The following is a description of a gene set: Global Genome Nucleotide Excision Repair (GG-NER) Mouse Gene Set: REACTOME_GLOBAL_GENOME_NUCLEOTIDE_EXCISION_REPAIR_GG_NER species: Mus musculus, and this is the list of marker genes: Rad23a, Rpa2, Cops4, Sumo2, Ccnh, Ercc2, Ercc5, Pias3, Rfc2, Cops2, Ube2n (NCBI Gene Id 93765), Rpa3, Rnf111, Gtf2h2, Polk, Ddb1, Cul4b, Ino80c, Cdk7, Pold4, Gtf2h1, Sumo3, Rad23b, Gtf2h3, Cops3, Pole3, Pold1, Parp2, Rps27a, Rfc3, Uba52rt, Gtf2h5, Pole2, Mcrs1, Ubc, Uba52, Ino80e, Cops6, Rfc4, Yy1, Rfc1, Ruvbl1, Cul4a, Nfrkb, Parp1, Cops7b, Pole, Ubb (NCBI Gene Id 22187), Chd1l, Sumo1, Gtf2h4, Pias1, Ino80b, Actr5, Cops7a, Cops8, Tfpt, Ube2i, Actb, Mnat1, Ino80d, Ddb2, Rpa1, Ino80, Ercc3, Pold2, Ercc4, Pold3, Gps1, Pcna, Rbx1, Cetn2, Cops5, Pole4, Ube2v2, Rfc5, Actr8, Xpc, Xpa, Actl6a, Ercc1, Usp45